Given this list of marker genes TRBV14, VAMP7, TRGV8, KCNA2, IL23R, SRPRB, DERL1, EMC7, DLG2, TRPV5, PIK3R2, SGCE, KCNJ16, GABRR2, CACNG5 (NCBI Gene Id 27091), TBC1D5, GABRB1, CACNB1, NDUFC2-KCTD14, SKAP1, KCNK1, IRS1, SEC61G, CSF2, SPG7, TRBV7-3, KCNK12, LAMP2, HERPUD1, CNTNAP2, AP2M1, CSF2RA, RET, BCS1L, CACNG2, KCNG4 (potassium voltage-gated channel modifier subfamily G member 4), APC, SYNRG, TRAV38-2DV8, GNA12, S100A9, TGFBR2, TGFBR3, USE1, CDH3, PIK3C3, HLA-A, KCNE4, GNAO1, IGHE, SLC17A8, DUOX2, STAC3, SEC23B, MT-ND2, CACNG1, ENTR1, ACVR2A, TMEM258, CHUK, PKD1L3, TRBC1, ITGA6, NDUFB8, ANKFY1, MR1, TRAF6, ATP1B3 (ATPase Na+/K+ transporting subunit beta 3), STON2, BTBD8, SEC11A, CDH6, AP3D1, TRGC1, SNX2, TRBV5-6, TRBV2, HFE, CACNA1H, UTRN, KCNIP2, RYR1, KCNN1, ADAM8, SLC18A3, GABRR1, TRAV9-2, GNAS, SYNE4, TRBV16, CACNA1A, SCYL1, ACVRL1, C2CD6, GNG14, SPCS3, NCF4, HSPA9, KCNC2, SLC25A6, ATP5MC3, TLR1, KCNJ11, MAGEL2, CHRNB4, PHB1, FCGR3A, UNC80, EFCAB7, SNAP25, MT-ND5, KCNC1 (potassium voltage-gated channel subfamily C member 1), NDUFS7, CDH22, GRID1, KCNJ14, PSEN1, CATSPERG, GRB2 (growth factor receptor bound protein 2), CALR, HLA-DQA2, CD247 (CD247 molecule), NDUFB6, PKD2, HLA-H, CHRNA2, APBB1IP (NCBI Gene Id 54518), CORO1C, KCNJ12, VAMP8, SEC24C, NDUFA12, GNG12, KCNE3, NDUFA4L2, PGM5, CHRNA3, TRAV6, SHISA6, TFR2, TRPC1, HLA-DQB2, FAS, FADD, ATP6V0A4, MLEC, MVB12A, SNTA1, UQCRFS1, CHRNA7, PAM16, ATP5MGL, IL18R1, CHRNB1, TLR4, ATP5MG, KCNJ5, COPB2, TREX1, ATP6V1C1 (ATPase H+ transporting V1 subunit C1), ITGB4, GABRD, GJC2, TMEM262, ANO2, NDUFB5, VPS37D, HLA-G, CACNB4, TRAV23DV6, RHAG, TRBV25-1, CDH13, KCNH4, TOMM6, ATP1B1, VPS26B, VPS33B, NEO1, VDAC1, CHCHD6, SNX5, ABCA2, KCNA5, TRAV21, EPS15L1, GABRA4, SUN1, MT-ATP6, KCNG3, CHRNA4, GYPA, GNG11, C6, GNG5, ATP6V0D1 (ATPase H+ transporting V0 subunit d1), MICU1, VTI1A, SLC26A6, GNGT1 (G protein subunit gamma transducin 1), TRDV3, CASP10, TIMM17A, SLC6A3, KCNK10, KCNC3, HCN3, CDH26, CACNA1I, GNAT1, TRAV1-2, TMEM249, SEC61A2, TRAV26-1, IGF1R, IL6, COX6B1, RAC1, CATSPER4, SEC13, IMMT (NCBI Gene Id 10989), ITGA1, PIK3CA, STX6 (syntaxin 6), TRAV12-1, GNG10, CHMP4A, POMT1, GNB1, TNK2, MT-ND4L, MTX1, ITGBL1, ITGB8, MEP1A, TOMM40L, RAMP2, COX5A, KCNK17, VPS16, TRDC, IFNLR1, SLC25A4, SGCG, GP1BA, SUN3, NDUFB3, TRAV16, AMIGO1, HOOK1, TRBJ1-4, TRAV17, GPAA1, ATP4A, C9, FXYD4, TAP2, TRDJ1, SNX3, RPN2, KRT19, AP1S1, MEP1B, UQCRFS1P1, DNAJC15, KCNJ6, PRKCA, C5, CACNA2D1, TRIM27, GRM1, TRAV13-2, CHMP2B, RIPK1, TRGV2, LAMTOR1, INSIG1, SEC61B (NCBI Gene Id 10952), GRPEL1, TRBV6-6, PDSS1, ABHD12, CLINT1, HMGB1, GABRB2, SLC38A9, RAMP3, DNAJC11, GLRA3, SYNJ1, GNB3, LIN7A, CYC1, STX7, GYPB, CACNB2, TOMM70 (NCBI Gene Id 9868), GNGT2, NDUFS4, VPS29, AKAP6, MICU2, CDH11, GJA1, DNAJC19, ATP6V1F (ATPase H+ transporting V1 subunit F), CLDN17, HLA-DOB, ATP6V1A, PIGQ, SLC9A1, PIK3CB, ITGA7, TRAV8-3, GP5, GRIN1, FLNA, GPR89A, TRAV29DV5, STING1, KCNMB4, HLA-F, CAV1, CSF2RB, CALM3, TRGV9, GNAL, NDUFA1, DLG1, TAP1, PDE4B, DIPK2A, NDUFA10, TRBJ1-5 (NCBI Gene Id 28631), AP5S1, LIN7C, TRAV12-3, VAC14, OST4, ITGB2, ITGA11, CLCN2, DAD1, VWC2L, MTX2, DIAPH3, CHRNB2, GFRA1, GABRG1, TRBV5-5, ATP6V0E2, TRPM4, ALG14, ATP2A1, AFDN, HSPD1, GP1BB, FZD8, KCNH6, WDR93 (NCBI Gene Id 56964), TTYH1, TRBV3-1, CLIC4, EFCAB9, STX1B, EPN1, TRBV27, TRPC6, TRAV41, KASH5, CASP8, SLC7A5, RAC3, NDUFA4, PIGP, GLRA1, CASQ2, GJB2, NDUFS5, KCNK7, LIN7B, HLA-DPA1, KCNF1, GABBR1, UBAP1L, SCN2A, TRBV6-7, SEC31B, GPR89B, TOMM22, TRBJ2-7, SCN4A, CLTB, COPA, CATSPERZ, AP3S2, C15orf48, S100A10, HTR3B, TRBV5-1, COL13A1, STX3, OSTC, SCN8A (sodium voltage-gated channel alpha subunit 8), PSG9, TRDD1, NCSTN, SNAP29, KCNS3, KCNJ10, TRBV23-1, NDUFA3, CHMP3, CD79B, EMC9, GJA8, DMAC2L, GRIA2, CLTA, CTNNA1, TAPBP, LILRA4, DAG1, EMC2, EMC8, ITGAM, VCAM1, SCN9A, TRBJ1-3, SLC17A7, KCNMB2, B2M, BECN1, LRRC8A, ITGB5, AP3B2 (adaptor related protein complex 3 subunit beta 2), KCNK16, ATP5F1E, KCNV1, FAF1, OLFM3, TRAV1-1, NDUFB11, ANK1, CD3G, TGFBR1, AFG2B, HTR3D, SLC1A3, ATP6V0C, HTR3C, KCNK4, ATP6V0A2, ATP6V0A1, VPS33A, COX7A2, SNTB1, TRAV12-2, VAMP1, GNAT3, NDUFS2, TRBJ1-6, MICU3, TRBV10-2, KCNH7, TRBJ2-5, UQCRB, PIK3CG, GRIN2A, GJA10, TMEM199, KCNMB3, TRAF5, NDUFV2, ITGB1, ROMO1, HLA-DPB1, TRAV3, CPLX4, SCN7A, KHDRBS1, GNA11 (G protein subunit alpha 11), TMEM37, COPZ1, KCNQ2, CPLX3, PHB2, DPP6, CHRFAM7A, TRBJ2-1, KCNS2, MT-CYB, SNX6, ATP6V1E2, STX8, OS9, TRBV5-4, NECAP2, AP3B1, MTCO2P12, MT-CO2, KCNA10, RNF31, KCNIP4, PIGC, STX16, PIK3R1, SCLT1, SGCD, ATP1B4, KCNE1, COX6B2, ITGA4, EXT2, KCNA7, MMGT1, AMFR, HLA-DQA1, TRBC2, GNA13, GJD4, KCNB1, KCNJ15, TRBV6-1, NOX5, CAV2, GABRP, COPB1, ATP5F1C, GABRR3, VPS41, ASPH, NDUFA5, CPT1C, VCP, PTPN6, SYNE1, INHA, EVC2, ATP5MC2, SCN1B, PTK2B, INSR, SCN4B, MPC2, EPN3, TRBV7-7 (NCBI Gene Id 28591), GABRQ, ATP6V1G1, NDUFA6, STX4, SEC63, APH1B, CHCHD3, COX6A1, GNG2, INSIG2, TOMM40, ENTHD1, CFLAR, LAMTOR2, TRBV11-2, C8A, GABRA5, CACNA1S, ATP1A3, TSPAN33, CNGA4, TRBV7-9, ATP6V0B, AP1B1, ZAP70, ATP5MK, SDHC, RNASEK, AP5M1, GPR156, CDH5, PDIA3, ATP6V1E1, UQCRHL, RAB7A, KCNC4, CACNA2D3, GP9, CD6, YKT6, TMED10, LY96, AGK, MT-ND3, SHISA8, MCUB, PACC1, HLA-DRB1, HLA-DRB4, SCN3B, TRAV5, SNX4, CHMP1A, VPS37B, ATP6V0D2, AFG3L2, KCNH1, IKBKB (NCBI Gene Id 3551), CNIH2, GLRA2, ATG14, TRBV29-1, GNG3, IL6R, BMPR1A, TRBV10-3 (T cell receptor beta variable 10-3), CASP3, GJA9, CRB2, PDSS2, ATP6V1C2, TRBV30, SPCS2, HTRA2, ABHD6, TRBJ1-1, SUN5, TRGC2, SEC31A, NALCN, PIK3CD, CNGA1, PSENEN, TRAV36DV7, SNTB2, TRBV7-4 (NCBI Gene Id 28594), NDUFC2, KRTCAP2, STT3B, BCL2, SSR4, ATP6V1B2, DRD1, MT-ATP8, HLA-DRB3, EMC1 (NCBI Gene Id 23065), CLCC1, SYN2, ATP1A2, SGCZ, NCF1B, SESTD1, SNTG1, PIGT, BEST2, NDUFS6, ITGB7, UBXN7, EPN2, VAMP4, GJA5, HLA-DMA, TRAC, GNAZ, EVC, GJB6, KCNS1, BECN2, PIK3R4, UQCRC1, TRBV9, LRRC38, ABCC8, PDCD6, CACNA1G, WNT3A, CDH19, TRDV2, KLHL12, LRRC8C, FXYD1, TIMM44, HTR3A, SRPRA, DCTN1 (NCBI Gene Id 82109), CATSPER1, COX5B, CALM1, CD8A, EMC4, AP1S3, TRAV13-1, ATP5F1A, TRPM5, CRB3, TRBV5-7, STT3A, TRAT1, UBE2J1, PTPA, CACNB3, TRAV4, VAMP3, KCNIP3, ABCG8, COPG2, ATP12A, NDUFAF2, TYK2, UGT3A2, MFN1, PKD2L1, COX4I2 (NCBI Gene Id 84701), EPS15, HM13, GNA14, LRRC8E, GRID2, TAPBPL, GNB4, KCNH8, KCND2, KCNA4, IGF1, CACNA1E, VPS18, GRIK3, NCF2, TRAV19, LRRC8B, ATP5ME, KCNV2, SNX8, CLBA1, CHCHD10, GJA3, NHERF1, MAP3K5, NDUFB7, KCNG1, TRBV4-2, CLCN1, KCNQ5 (NCBI Gene Id 56479), CD3D, PIK3R3, TRBV20-1, CATSPERB, GRPEL2, TIMM22, MAGT1, LRRC55, GJB7, NDUFA9, GNG8, TRAV30, MCU, TRBV7-1, C7, GNG4, CACNG8, BEST1, IFNL1, SEC11C, VIPAS39, GJB4, SAMM50, CHRNA5, SCN1A, VPS8, TRBV12-3, RYR2, TRBV6-4, TOMM20L, CYBB, GRIN2B, ATP6V1B1, CDH20, TRGV4, ITGB6, NDUFS8, RYR3, AP2A1, IL13RA1, ERBB3, PRKACA, KCNH5, PLN, STX12, SCNN1D, CTNNB1, AP1M1, CHMP5, CLIC3, CNGA3, FLOT1, BNIP1, PIGU, NOXA1, KCNJ13, SEL1L, MYCBPAP, AP1M2, TMED7, GOSR2, SNAP23, TMED3, ALG13, MT-CO1, CPLX1, ITGAV, HLA-C, PIK3R6, UVRAG, CLIC1, TRBJ2-6, SYVN1 (NCBI Gene Id 84447), STXBP5L, NDUFB10, SHISA7, IGHM, GJB1, CRB1, KCNJ1, SSPN, STON1, HLA-DOA, BEST3, SEC24D, IL10RB, AP5B1, CALCRL, AP1S2, VPS36, SGIP1, MT-CO3, GRIA4, CLCN7, TRAV14DV4, DCHS1, KCNQ4, KCNA1, TF, TRBV7-6, IGF2R, BAIAP2L2, AFTPH, TSPAN32, SRP9, GABRE, TRADD, TRBD1, UQCRH, GJC3, CLCNKA, HCN1, TRPV6, CNGB3, TRAV8-1, KCNJ2, TIMM17B, NOX3 (NADPH oxidase 3), LRP6, TOMM5, COX6C, ATP5PB, CACNA1D, UGT3A1, CACNA1C, SGCB, SPAAR, KCNK2, GJA4, SLC25A31, SDHA, EPB42, CACNA1B, GRIK2, CNIH3, ATP5F1EP2, CATSPER2, PKD1, UQCRQ, GRIN3A, TRAV7, GOSR1, SCN10A, AQP1, CLTCL1, DENND5A, EGFR, CDH4, HLA-DRB5, FKBP1B, COPG1, CD14, CHRNG, TRPC7, ATP5MJ, KCNJ8, GNB5, NDUFB1, EMC6, CHMP4BP1, PDGFA, IL2RB, ACVR2B, GJD3, NDUFS3, TRPC4, SNX12, SCN11A, KCND3, NOX1, GNAI1, CACNA2D4, KCNQ1, CDH2, TFRC, NDUFAB1, TRBV12-5, TRGV5, CNGB1, CLIC6, PIGK, CDH23, ITGAX, NDUFV1, ITGAE, SNF8, SDCBP, SREBF2, ARL6, PIGS, CATSPERE, TRAV35, COPZ2, AP4E1, KCNU1, RHCE, TRBV24-1, OLFM2, CHRND, GRIN3B, VPS39, CD8B, GABRA3, NDUFV3, TRBV5-3, VDAC3, TRPC3, CDHR3, ITGB3, GNAI2, KCNK15, ZACN, ATP5PF, ITGA8, CDH24, TSNARE1, COX7A2L, KCNG2, STX19, HTR3E (NCBI Gene Id 285242), BET1 (Bet1 golgi vesicular membrane trafficking protein), CACNA1F, ITGA2, KCNA3, IMMP1L, CATSPER3, ITGAL, EMC10, GNAI3, RPN1, ATP1A4, GABBR2, APOOL, ACVR1C, LRP5, ATP6V1D, CATSPERD, FAM8A1, NCF1C (neutrophil cytosolic factor 1C (pseudogene)), SACM1L, BAK1, SMDT1, TRAV24, VPS25, AP2B1, CNEP1R1, ATP5PO (ATP synthase peripheral stalk subunit OSCP), IL6ST, TIMM9, ITGA3, COPE, SLC17A6, BET1L, AP1G2, STX1A, CD34, COX7B2, TTYH3, VPS26A, NDUFA11, SCNN1B, SELENOS, CDH1, RP9, PKD1L1, NRBF2, KCNH2, C8G, SEC24A, ATP6V1G2, GRIA3, TRAJ3, UQCR11, COX7A1, CD4, CNGA2, DLG4, ABCB8, TRAF2, ANO1, CIDEB, ERBB2, ITGA2B, DDOST, BIRC2, KCNE5, ABCC9, KCNB2, CYBA, SNX1, UBAP1, LAMTOR3, VWC2, SYNE2, NRN1, GNG5B, LRRC52, NDUFA13, FXYD2, SYNE3, TRAV22, CHRNA6, SCAP, ORAI1, KCNJ9, UQCR10, OSMR, AP3S1 (adaptor related protein complex 3 subunit sigma 1), RAMP1, CLIC2, HLA-DRA, TRDV1, MT-ND1, TRAV40, HSD17B12, SPAG4, PSEN2 (presenilin 2), CD3E, STX11, ATP6V1H, GJE1, KCNAB3, TRAV10, ANXA2, CNTFR, KCNK5, EMC3, CCDC115 (coiled-coil domain containing 115), ALCAM, COX8A, STX10, CEACAM1, CAV3, MICOS13, STXBP5, MPC1, C8B, CACNA2D2, PDE4D, ATP6AP2, GABRG2, TIMM50, UEVLD, VTN, CHMP6, LRRC8D, GLRB, TRBJ2-4, SHC1, LIME1, KCNAB1, KCNJ18, PICALM, CD74, VTI1B, CDH12, AP4S1, NAPA (NSF attachment protein alpha), TIMM10, TRGV10, SCN2B, TIMM21, NECAP1, AP5Z1, TOMM7, RNF139, CTDNEP1, NDUFA8, NDUFA7 (NCBI Gene Id 4701), DPP10, SCN5A, TRAV9-1, CHMP4B, SORBS1, ABCB6, STX18, TTYH2, PLEKHA7, RAC2, SAR1A (NCBI Gene Id 56909), CHMP1B, MFSD8, AP3M2, SLC1A6, OSTM1, TLR6, LRP1, CDH17, CDH7, DLG3, CLIC5, TRAV8-4, VPS37C (VPS37C subunit of ESCRT-I), TRGV11, GNG7, BMP2, COX8C, IMMP2L, NAPG, PDGFRA (NCBI Gene Id 5156), ATP5MF, ATP4B, COX7B, SNTG2, FKBP1A, CACNG4, TRAV20, ARCN1, TRBV7-2, MVB12B, KCND1, KCNJ4, ATP5PD, TOMM20, CHRNB3, SHISA9, TRGV1, SEC23A, CACNG7, CTTN, GJD2, CHMP7, GNG13, ERN2, TRBV13, ELOVL6, APH1A, TSG101, APOO, KCNMA1, COX7C, TCIRG1, STX17, AKAP9, CTNNA2, TRAV25, TIMM23B (NCBI Gene Id 653252), BLOC1S6, AP3M1, IL2RA, SDHD, FLOT2 (flotillin 2), TIMM23, EPS8, CFTR, ITGA5, SDHB, HLA-DMB, NCF1, CBL, TRBJ2-2, KCNJ3, KCNK6, TRAV34, JAK2, STX2, INSRR, MPP7, DOC2B, IL12RB1, HJV, GJB5, MS4A2, CACHD1, ERN1, TRAV2, GABRG3, KCNQ3, CACNG3, ATP5MC1, CLDN4, BEST4, CLMN, GABRA1, TIMM10B, GRIA1, GJB3, SUN2, CHMP2A, CACNG6, PIGH, CDH10, KCNH3, VPS35, SPCS1, ATP6V1G3, TRAV8-2, GNB2, TRBV11-1, TRBV11-3, ATP6V0E1, GJC1, TRBV6-8, TRBV4-1, TLR2, MT-ND6, ADAM10, SLC4A1, HLA-DQB1, TRAV18, TMEM109, NOXO1, TRMT10B, KCNIP1, COX6A2, CCDC51, LAMTOR4, NAPB, BMPR1B, CD79A, TRBV17, HLA-B, ATP5F1D, DPM2, ABCG5, SLC25A5, ATP1B2, LRRC26, NDUFS1, CD40, DIABLO, GRIN2D, TRAV27, AP2A2 (NCBI Gene Id 25955), TUSC3, CHMP4C, ATP1A1, ATP2A2, TRBV6-5, TRPC5, LAMTOR5, CHRNA9, UFD1, ANO6, DUOX1, AP1G1, CDH15, MICOS10 (NCBI Gene Id 440574), BAX, FCER1G, TRBJ1-2, CDH8 (NCBI Gene Id 1006), SCNN1A, ATP5F1B, ARL6IP1, SLC3A2, ATP6AP1, SLC1A2, FAF2, SAR1B, LYN, SEC11B, NDUFB4, NDUFA2, KCNMB1, SCN3A, PIGA, TRAV39, GRIK5, SYK, PIGY, TRAF3, DMD, JUP, TRAV38-1, NCALD, STX5, NDUFB9, PORCN, PIK3R5, GNA15, KCNAB2, TIMM29, UQCRC2, CLCNKB, UBXN1, COX7A2P2, TRBV18, GABRA2, HCN2, ITGA9, AHNAK, SNAP47, NDUFB2, SGCA, HOOK3, CPLX2, PPIF, GRIK1, TPCN2, VDAC2, TRIL, TRBV28, SEC24B, CLTC, TRGV3 (NCBI Gene Id 6976), ITGA10, GABRB3, TRAV8-6, TRBV12-4, MARCHF6, CDH18, NOX4, KCNK13, AKTIP, AP4M1, TPCN1, TRBJ2-3, CTNND1, IL18RAP, SNX27, PEF1, PDZD11, KCNN4, CDH9, DENND4C, ITGAD, AP2S1, HVCN1, HCN4, GRIN2C, ABCD4, MTX3, NDUFC1, VPS37A, TRBV10-1, VAMP2, APC2, SEC61A1, CALCR, CHRNA1, HSPA2, GNAQ, KCNE2, KCNA6, GNAT2, TRAV26-2, SUMO1, CALM2, AP4B1, GABRA6, TRBV19, ACVR1, GRIK4, HSPG2, COX4I1 (cytochrome c oxidase subunit 4I1), MT-ND4 (mitochondrially encoded NADH:ubiquinone oxidoreductase core subunit 4), HOOK2, RNF125, EMILIN1, CHRNA10, DRD2, HLA-E, ACVR1B, NPLOC4, CHRNE, VPS28, VPS11, SCNN1G, here is a description of the gene set: Any protein complex that is part of a membrane. studied in species Homo sapiens Human Gene Set: GOCC_MEMBRANE_PROTEIN_COMPLEX